The following is a description of a gene set: studied in species Mus musculus The multiplication or reproduction of cardioblasts, resulting in the expansion of the population in the heart field. A cardioblast is a cardiac precursor cell. It is a cell that has been committed to a cardiac fate, but will undergo more cell division rather than terminally differentiating. Mouse Gene Set: GOBP_CARDIOBLAST_PROLIFERATION, and this is the list of marker genes: Eya1, Gng5, Six1, Tbx5 (T-box 5), Hes1, Tbx1, Notch1, Pim1, Hand2, Isl1, Mks1, Ctnnb1